The following is a description of a gene set: species: Homo sapiens Latent membrane protein 1 (LMP1), an oncoprotein encoded by Epstein-Barr virus (EBV), is an integral membrane protein, which acts like a constitutively active receptor. LMP1 is critical for some facet of EBV's induction and maintenance of proliferation of infected B cells. It, in part, mimics signaling by the CD40 receptor and has been implicated in regulating proliferation, survival, or both properties of EBV-infected cells. We established a conditional LMP1 allele in the context of the intact EBV genome to define the immediate-early cellular target genes regulated by LMP1 in order to assess its contributions to infected human B cells. The functional analysis of this conditional system indicated that LMP1 specifically induces mitogenic B-cell activation through c-myc and Jun/AP1 family members and confirms its direct role in upregulating expression of multiple genes with opposing activities involved in cell survival. LMP1's signals were found to be essential for the G1/S transition in human B cells; cells lacking LMP1's signals are cell cycle arrested and survive quiescently. LMP1's activities are therefore not required to maintain survival in nonproliferating cells. LMP1 does induce both pro- and antiapoptotic genes whose balance seems to permit survival during LMP1's induction and maintenance of proliferation. Human Gene Set: DIRMEIER_LMP1_RESPONSE_LATE_UP from publication Dirmeier U, Hoffmann R, Kilger E, Schultheiss U, Briseño C, Gires O, Kieser A, Eick D, Sugden B, Hammerschmidt W (PMID 15674340) Cluster 3: genes up-regulated in B2264-19/3 cells (primary B lymphocytes) within 60-180 min after activation of LMP1 (an oncogene encoded by Epstein-Barr virus, EBV)., and this is the list of marker genes: LITAF, ETF1, SLC7A1, VOPP1, POM121, NFKB1, MARCKS, PIEZO1, SERPINB9, BZW1, PLEK, SPIB, CFLAR, GARS1, JADE2, IL4R, TRIP10 (thyroid hormone receptor interactor 10), TUBB2A, CD58, MTHFD2, RPS28, ADGRE5, CARS1, HSD17B10, RHOG, RFTN1, RUNX3, FASN, AHDC1, HMOX1, MDFIC, ANP32A, CSNK1D (NCBI Gene Id 1453), NBN, TRAF1, TNFRSF1B, ATP13A3, SLC20A1, IRF5, CRIP1, FEZ1, TNIP1, SWAP70, FSCN1, SLC7A5, LYN, CCL22 (C-C motif chemokine ligand 22), STIP1, DHCR7, SRRT, NFKB2 (nuclear factor kappa B subunit 2), OTUD4, STAT5A, BATF, SQSTM1, CD40